Given this list of marker genes INS, SHISA7, SQSTM1, PAIP2, FXR1, RELN, MIR30B, MME, PRKAR1B, TYROBP, EPHA4, ADORA2A, APOE, NF1, NSG1, PDE9A, ADORA1, ADCY1, ARC, LGMN, GSK3B, STAU1, EIF2AK4, ADCY8, APP, ABL1, SLC18A3, EPHB2, NCSTN, IGSF11, LILRB2, ZDHHC2, AGER, AKAP5, FAM107A, SHANK3, YTHDF1, CYP46A1, PRNP, DRD2, C22orf39, PTN, NRGN, CHRNA7, CREB1 (NCBI Gene Id 1385), here is a description of the gene set: Human Gene Set: GOBP_REGULATION_OF_LONG_TERM_SYNAPTIC_POTENTIATION Any process that modulates the frequency, rate or extent of long-term synaptic potentiation. studied in species Homo sapiens